The following is a description of a gene set: species: Homo sapiens Any process that activates or increases the frequency, rate or extent of adipose tissue development. Human Gene Set: GOBP_POSITIVE_REGULATION_OF_ADIPOSE_TISSUE_DEVELOPMENT, and this is the list of marker genes: TRPM4, PPARG, NCOA2 (nuclear receptor coactivator 2), NCOA1, FAM83A, LPL (NCBI Gene Id 4023), NR1H4, GHRL, SIRT1, PRKAA1, SORL1